Given this list of marker genes CPSF3, SRSF5, LSM2, RNPS1, SNRPG, TMED10, SRP54, FUS, HNRNPA1, HNRNPU, NCBP2, PTBP1, PRMT1, HNRNPAB, SNU13, CDC40, PCBP2, HNRNPL, RNGTT, RBM17, U2AF2, SNRPB, SF3B5, SRRM1 (serine and arginine repetitive matrix 1), SPOP, SF3B2, SRSF6, SF3A1, CPSF2, HNRNPR, SMC1A, LSM7, CLK4, SRSF2, PRPF18, DNAJC8, SRSF1, PRPF8, CLP1, TRA2B, XRN2, DDX20, PAPOLA, SRSF3, SF3B1, SF3B4, SUGP1, SRSF9, PRMT2, PPM1G, RBM5, DHX9, SRSF7, NXF1, CPSF4, CLASRP, SREK1, PRPF4, CLK3, CELF2, CD2BP2, SNRNP40, HNRNPD, NCBP1, SF3B3, PHF5A, CSTF2, PTBP2, YBX1, METTL3, PSKH1, SFSWAP, SNRPE, SNRPA1, HNRNPH1, RBMX, TXNL4A, SUPT5H (NCBI Gene Id 6829), SNRPD1, HNRNPH2 (heterogeneous nuclear ribonucleoprotein H2), SUGP2, SFPQ, CELF4, NUDT21, DHX15, RNMT, DHX16, PRP4K, HNRNPA2B1, SF3A2, CLK2, EFTUD2, SNRPA, CSTF3, DHX8, SNRPD3, SRPK2, POLR2A, PABPN1, DDX1, PRPF3, SF3A3, PRPF40A, HNRNPK, SNRPN, SNRPB2, CLK1, U2AF1, HNRNPM, SRSF4, SNRPD2, CSTF2T, SRPK1, RBM39, RNU2-1, CELF1, SNRPF, CSTF1 (cleavage stimulation factor subunit 1), DICER1, CPSF1, DHX38, NONO, SRSF10, PRPF6, HNRNPC, SNRNP70, here is a description of the gene set: Human Gene Set: WP_MRNA_PROCESSING mRNA processing studied in species Homo sapiens